Given this list of marker genes SYNE1, PI4K2A, ALS2, SPG11, AOPEP, ANO3, ATP1A3, SPTLC1, KMT2B, DLAT, FTL, VPS16, SIGMAR1, FUS, here is a description of the gene set: Human Gene Set: HP_ARM_DYSTONIA Arm dystonia A type of dystonia (abnormally increased muscular tone causing fixed abnormal postures) that affects muscles of the arms. species: Homo sapiens